Given this list of marker genes Loxl3, Batf, Tnfsf18, Tbx21, Il23a, Ep300, Lgals1, Slamf6, Cd69, Stat3 (NCBI Gene Id 68733), Il6, Ly9, Irf4, Brd4, Il6ra, Opa1, Brd2, Otud5 (NCBI Gene Id 54644), Tgfb1, here is a description of the gene set: studied in species Mus musculus The process in which a CD4-positive, alpha-beta T cell becomes committed to becoming a T-helper 17 cell, a CD4-positive, alpha-beta T cell with the phenotype RORgamma-t-positive that produces IL-17. Mouse Gene Set: GOBP_T_HELPER_17_CELL_LINEAGE_COMMITMENT